Given this list of marker genes DDX20, SH3BP2, TUSC2, FMR1, SPDEF, CLMP, FKBP5, GPR171, LHFPL2, SLFN12L, NAA20, SLC7A3, SLC24A3, RAD51, CDC42EP2, AKAP9, DESI2, BCAT1, HSPA4, E2F8, ASPHD1 (NCBI Gene Id 253982), VMP1, DSCAML1, PRF1, BOK, C19orf12, CDCA8, DTX2, BARD1, CFLAR, PARD3B, SLC25A18, RFC3, HLA-E, FANCD2, HSPA5, CXCL3 (C-X-C motif chemokine ligand 3), PLXNA4, CRYAB, MPEG1, PSMA5, TOR1AIP1, FAM25C, CGAS, PI15, LITAF, DNER, UCN, TAC1, ADAD1, XYLB, YIPF1, GPR182, NEK2, C1S, TGIF2, NR0B1, DTX3L, TBK1, HDHD3, SELENOW, C17orf99, MAPK13, DCTN4, SAMHD1, BHLHA15, MUC15, BIRC3, CCDC102A, NAT14, SAP30, ERCC6L, PRELID2, BOLA1 (bolA family member 1), EHD4, SIM1, EEIG1, TMPRSS11E, CAND1, RELB (RELB proto-oncogene, NF-kB subunit), FOXK2, CCDC85A, GATA1, P4HA1, SERPINE2, KANK4, SLC5A3, PGPEP1, ETV6, ATN1, STAT1, GGT1, PIH1D1, CAPN8 (calpain 8), CHORDC1, ARHGAP30, SNX27, PRNP, RBM15, LMAN2L, CLEC5A, PTGER3, ABI3, TRIM14, WBP4, SBNO2, IL2RA, ARHGAP11A, MARS1, IFI35, ITPK1, ACTRT2, CENPF, MED6, IFI44, VPS54, CLIC4, PHB2, SCAND1, ASB11, PILRB, GREM1, CNDP2, POP1, BST2, CD2, ZNF365, SLPI (secretory leukocyte peptidase inhibitor), TBRG1, LPXN, USP9Y, SASH1, COX6A2, NFATC4, JMJD6, SETDB2, SSUH2, CYSLTR2 (NCBI Gene Id 57105), CCND2, RBL1, SLC9B2, OSM, DTX4, SERPINB1, RABGEF1, UBFD1, JUP, SOCS1, GHITM, TCOF1 (NCBI Gene Id 6949), KDM4D, LYVE1, SHC3, HOOK2, GLRA3, HM13, MYORG, LUZP1, HCK, PFAS, AP1S3, DCLRE1C (DNA cross-link repair 1C), SPATS2, IFIT1B, COX18, TNFRSF18, VAC14, SLC7A5, INSL6, SEMA7A, APOBEC1, NUP210, TNFSF10, SAMSN1, NMI, MAX, NID2, PPM1K, NGEF, PKN1, PCGF5, ELOVL6, ACOT7, DRAM1, TMUB1, SLC51A (solute carrier family 51 member A), CTRL, MYCBP2, CALB1, EIF2B2, PARP9, C15orf48, TRIB3 (tribbles pseudokinase 3), SKAP2, OASL, SERPINI1, UBE2L3, APOC1, USP37, LRR1, here is a description of the gene set: studied in species Homo sapiens from publication Kaji T, Ishige A, Hikida M, Taka J, Hijikata A, Kubo M, Nagashima T, Takahashi Y, Kurosaki T, Okada M, Ohara O, Rajewsky K, Takemori T (PMID 23027924) To obtain insight into the genetic basis of the increase of functional activity of memory B cells over time, we compared the gene expression profiles of day 7 and day 40 NP-specific/IgG1 memory B cells, GC B cells and plasma cells in immunized WT mice and naïve B cells, before and after activation in vitro. Human Gene Set: GSE11961_GERMINAL_CENTER_BCELL_DAY7_VS_PLASMA_CELL_DAY7_UP Genes up-regulated in day 7 germinal center B cells versus day 7 plasma cells.